Given this list of marker genes Lrrtm1, Ubqln2, Anxa2, Cd300a, Atg5, Apoc3, Plscr1, Prtn3, Picalm, Ank3, Neu3, Wdr54, Syt11, Pip4p2, Dlg4, Cd300lf, Pacsin3, Abca2, Unc119, Itgav, Rack1, Atg7, Fcgr2b, Snx33, Sirpa, Mtmr2, Lrsam1, Pcsk9, Ankrd13d, Scamp5, Rubcn, Epha3, Nr1h3, Tlr2, Adipoq, Tgfb1, Apoc2, Appl1, Fmr1, Pten, Snx3, Sh3gl3, Atxn2, Mctp1, Snph, Itgb3, Apoc1, Hmgb1, Csk, Apoc2l, Cnn2, Necab2, Ankrd13b, Stx1b, Rabgef1, Sdcbp, Atg3, Prom2, Nr1h2, Lgals3, Cav1, Ankrd13a, Siglece, Sftpd, Cd47, Rin3, Abca7, Dysf, Tsc2, Lrrtm2, Lrpap1, Pacsin1, Pacsin2, here is a description of the gene set: Any process that stops, prevents, or reduces the frequency, rate or extent of endocytosis. Mouse Gene Set: GOBP_NEGATIVE_REGULATION_OF_ENDOCYTOSIS species: Mus musculus